The following is a description of a gene set: electronically inferred by orthology from the curated human pathway studied in species Mus musculus part of: Metabolism of amino acids and derivatives This event has been computationally inferred from an event that has been demonstrated in another species.<p>The inference is based on the homology mapping from PANTHER. Briefly, reactions for which all involved PhysicalEntities (in input, output and catalyst) have a mapped orthologue/paralogue (for complexes at least 75% of components must have a mapping) are inferred to the other species. Reactome Pathway: Alanine metabolism, and this is the list of marker genes: Gpt